The following is a description of a gene set: species: Homo sapiens Any part of a cell where non-isotropic growth takes place. Human Gene Set: GOCC_SITE_OF_POLARIZED_GROWTH, and this is the list of marker genes: KLC1, CDKL5, OTX2, ADGRL1, EXOC6, KIF21B, NGEF, TRAK2, SIRT2, L1CAM, ZFYVE27, AMFR, IQGAP1, CALM3, MAPK8IP3, TWF2, SETX, ELAVL4, MAP1B, DCTN2, MYH10, ATCAY, PTCH1, NRSN1, PINK1, IGF2BP1, CTTN, SHTN1, MAP2, EPHA4, TUBB3, PALLD, APBB2, DVL1, FKBP15, TENM2, GPRIN1, GDPD5, TRAK1, MAP3K12, NRXN1, STMN4, RASGRF1, EXOC8, PCDH9, STMN3, BOC, INPP5J, EXOC3, DSCAM, KIF21A, KIF5C, SCN11A, NEO1, CBL, FRMD7, DOCK7, STX3, CSNK1E, PTK2B, SLC2A13, EXOC7, PAFAH1B1, NGFR, FRY, RTN4R, ALS2, ACAP3, CRTAC1, PTPRO, SHANK2, ERC2, TSHZ3, RAC3, ADCY10, APP, COPG2, ZNF804A, MYH14 (myosin heavy chain 14), PPP1R9B, IGHMBP2, LRRTM1, DPYSL3, AUTS2, GPM6A, SNCA, CCDC120, NIN, DISC1, CBARP, CLASP2, LRRK2, TRPV4, GIT1, TAOK2, COBL, OLFM1, TRPV2, ABITRAM, ZPR1, FKBP4, ABL1, USP9X, HAP1, CDK5, FEZ1, PSEN1, FMR1, COTL1, PTPRS, PCDHGB1, TRPC5, THY1, FRYL, SIGMAR1, APBB1, KIF20B, TOR1A, BASP1, LRIG2, LAMP5, PREX1, FGF13, ITGA4, DTNBP1, COPA, LMTK2, EXOC4, CDK5R1, CYTH2, NEFL, ABI1, RUFY3, C9orf72, MYO5A, CTSZ, CNR1, FLRT3, ARHGAP4, CD2AP, CPEB4 (NCBI Gene Id 80315), CFL1, UNC5C, SYAP1, HSP90AB1, NECTIN1, NDRG2, MYO9A, TIAM2, KATNB1, DBN1, CDK5R2 (cyclin dependent kinase 5 regulatory subunit 2), SSH1, ITGA3, MAPT, STMN2, FLNA, GAP43, ANG, WHRN, EPS8 (NCBI Gene Id 2059), CIB1, FSCN3, SNAP25, PTBP2, FSCN1, ARPC3, ENO2, PI4K2A, GRM6 (NCBI Gene Id 2916), WDR47, MAPK8IP1, CRMP1, HSP90AA1, CXADR, DNM2